The following is a description of a gene set: Human Gene Set: GSE15930_NAIVE_VS_48H_IN_VITRO_STIM_IFNAB_CD8_TCELL_UP from publication Agarwal P, Raghavan A, Nandiwada SL, Curtsinger JM, Bohjanen PR, Mueller DL, Mescher MF (PMID 19592655) Genes up-regulated in comparison of CD8 T cells at 0 h versus those at 48 h after stimulation with antigen-B7-1. studied in species Homo sapiens Differentiation of naive CD8 T cells into cytotoxic effector cells requires three distinct signals- antigen (signal 1), costimulation -B7-1 (signal 2) and cytokine, either interleukin-12 or interferon-a/b (signal 3). Interaction of naive CD8 T cells with antigen and B7-1 programs cell division and proliferation whereas the presence of cytokines- IL-12 or IFNa/b promote survival, differentiation and memory establishment. In the absence of signal 3, the cells interacting with antigen/B7-1 undergo tolerance induction. The objective of this study was to elucidate the mechanisms how the provision of signal 3 promotes differentiation and averts tolerance induction in CD8 T cells. Trichostatin A is a pharmacological agent that inhibits histone deacetylase activity, hence regulating chromatin structure and gene expression and differentiation in many cell types. Gene signature profiles of IL-12, IFNa/b and trichostatin A stimulated cells were compared to elucidate the molecular mechanisms of gene regulation. Oligonucleotide microarray analysis is carried out to determine the extent and molecular nature of the CD8 T cell differentiation program induced by IL-12 or IFNa/b in concert with antigen and B7-1 signal., and this is the list of marker genes: GRIA3, INPP5K, BRAP, RPS6KB2, ING4, ZYG11B, GCG, PAK4, TBX2, ZFP57, PI4K2A, RNF123 (NCBI Gene Id 63891), NRTN, DNAJB4, FOSL2, EIF4H, TGIF2, CAT, VIP (vasoactive intestinal peptide), BPIFA2, BLOC1S1, PLEKHA5, CACNA1C, TRIM13, POLG2, MAP1LC3A, KIT, NR1D2, ARSA (NCBI Gene Id 410), CANT1, GALNT10, HLA-DOA, SERPINB4, NGEF, NTRK3 (NCBI Gene Id 4916), APP, GPX2, EPS15L1, IKZF2, S1PR1, USP3, MAP7, UBAP1, SH3BP1, TCF7, SLCO3A1, DENND2B, KCNH1, PLTP, CCR9, BSDC1, NQO1, CD1D, CA2 (NCBI Gene Id 760), CCKBR, TGFB3, TANC1, CLPS, TRAF2, STAT5A, CD276, SLC12A7, MUC13, NAP1L2, LMO2, MMP15, ARHGEF25, CYP3A43, TMED8, APOBEC1, LHCGR, JARID2, FBXW4 (NCBI Gene Id 6468), BCL3, C19orf12, DCT, PDE1B (phosphodiesterase 1B), GNA11, COQ10A, PMPCA, TPT1, CWC22, KCNQ1, NOTCH3, STK24, MFGE8, WT1, RPS27, F2RL1, SLC7A11, ZBTB16, ZFHX3, FGD3, PHC1, RPL12, RBM4B, GREM2 (gremlin 2, DAN family BMP antagonist), VIPR1, KIF3C, ABCC5, KRT1, RANBP10, LTBP1, GCSAM, HCN3, ANKH, ITPK1, PLAUR, ADRB2, CCDC93, SOX4, BMP6, PHF1, MCOLN2 (NCBI Gene Id 255231, mucolipin TRP cation channel 2), RALGPS2, MAL, CNGA2, FOS, FLT3LG, RETREG2, AP1B1, SPATA6, TEC, CAMK2B, TMEM191C, STX2, FLG, SORL1, MZF1, FRAT1, MKNK1, USP2, RPS6KA2, MSL2, SIAE (sialic acid acetylesterase), PHRF1, ST3GAL1, SLC11A2, RAB33B, CLTB, EFNB2, MAP4K3, SEMA4A, IL27RA, MOS, NMU, NAGA, MATK, NRIP1, NEDD4L, AKIRIN1, MPP3, ZNF292, QSOX1, B4GALT1, HINT2, NSG2, SH3GL1, ITGB3, GABBR1, C19orf48P, KIAA0319L, RPS15A, PEA15, BDKRB1, PKD1, METTL8 (methyltransferase 8, tRNA N3-cytidine), CDCP1, PSAP, FRMD8, KLF2, ZBTB20, DAO, MYORG, ARMCX2, ULK2, CUX1, TIMP2 (TIMP metallopeptidase inhibitor 2), HNF1A, SLC6A12 (NCBI Gene Id 6539), ERCC2, SDC3, SGPL1, FGF7, CLDN6, SLC39A4, SYNRG, RFX2, F9, SVIL, ABCG1, WBP1, SIAH1, SUMO2P7, SOX11, GZMA, RAPGEF4, JUN